The following is a description of a gene set: species: Mus musculus Any process that activates or increases the frequency, rate or extent of the chemical reactions and pathways resulting in the breakdown of substances. Mouse Gene Set: GOBP_POSITIVE_REGULATION_OF_CATABOLIC_PROCESS, and this is the list of marker genes: Pabpn1l, Pip4k2b, Cblb, Tlr9, Ikbkg, Usp20, Ubxn2a, Vdac1, Piwil4, Grsf1, Abca2, Vgll4, Samd4b, Htt, Sh3bp4, Ptpn1, Tnrc6c, Dtl, Cav1, Apoh, Amer1, Mlst8, Nupr1, Igf2bp1, Rnf152, Vps28, Gpsm1, Rhbdd3, Rnf40, Slc25a4, Ecscr, Clec16a (C-type lectin domain family 16, member A), Atg5, Ago2, Tnrc6a, Vsir, Rgma (NCBI Gene Id 244058), Pip4k2a, Wnt5a (NCBI Gene Id 77565), Sox9, Egln2, Qki, Esrrb, Axin2, Idua, Plk2, Slc35d3, Trim67, Ripk2, Csnk1a1, Rnf31, Ezr, Asb5, Fto, Adrb2, Sec22b (NCBI Gene Id 99656), Rab12, Eif2ak1, Ager, Hspa1a, Ago3, Hnrnpu, Trp53inp1 (transformation related protein 53 inducible nuclear protein 1), Fxr2, C4bp, Cop1, Bag2, Gja1, Ormdl3, Xbp1, Zc3h12a, Abcd1, Pan3, Lrp1, Hnrnpr, Trib1, Tsc1, Arnt, Mlx, Zyg11b, Irs2, Sumo1, Dab2, Cbfa2t3, Phkb, Mylip, Snf8, Irs1 (NCBI Gene Id 16367), Rab3gap2 (NCBI Gene Id 98732), Nanos3, Prkce, Mir451a, Akt1, Svip, Celf1 (NCBI Gene Id 98760), Ccny, Fgf21, Trf, Nrdc, Zfp36l3, Ptk2, Lin28b, Zdhhc19, Stx5a, Atg7, Mlh1, Apoa5, Lpcat1, Foxo3, Rb1cc1, Mettl3, Akt2 (thymoma viral proto-oncogene 2), Wfs1, Stub1, Ube2a, Bag6, Mlxipl, Eif2ak3, Rbx1, Polr2g, Nanos2, Sumo3, Apoa4, Deptor, Tut7, Zp3r, Sctr, Laptm5, Mir7578, Git1, Cnot1, Gga1, Rufy4, Supt5, Cnot7, Ythdf1, Optn, Gigyf2, Dapk1, Kcne2, Setd2, Pabpc1, Phkg2, Pink1, Ptk2b, Atm (NCBI Gene Id 77416), Bnip3l, Tut4, Chfr, Cnot6l, Smo, Hnrnpd, Apoe, Vcp, Mapk3, Kat2b, Hsp90aa1, Cnot6 (NCBI Gene Id 216722), Ubr4, Zc3h18, Rc3h1, Gata5, Hspb8 (heat shock protein 8), Tbk1, Gck, Gtpbp1, Trim8, Mul1, Apc, Tob1 (transducer of ErbB-2.1), Trim21, Map3k7, Abcd2, Mtln, Ralb, Adcy10, Mir144, Fbxo7, Hsf1, Csnk1e, Snx4, Pde12, Vps35, Samd4, Gpld1, Tmem67, Nub1, Adra2a, Rbx1-ps, Slc4a4, Prxl2c, Sqstm1, Sorl1, Rock1, Wipi1, Snx1, Prr5l, Hmox1, Dhx9, Slc25a5, Wdr24, Dcn, Uchl1, Nkd2, Patl1, Twist1, Cd81, Mtor, Btg2, Sumo2, Ube2v2, Elapor1, Cdc20b, Acsl5 (NCBI Gene Id 71879), Snx33, Sh3d19 (NCBI Gene Id 99866), Pcsk9, Faf1, Dhx36, Sgsm3, Mir196a-1, Trim23 (NCBI Gene Id 81003), Il1b, Zbtb20, Pabir1, Prickle1, Piwil1, Dnajb2, Dcp2, Sptlc2, Oaz2, Apoc2l, Wac, Zfp36, Trim13, Sesn2 (sestrin 2), Syncrip, Mefv, Supv3l1, Prkd1, Tnrc6b, Bax, Zer1, Apoc2, Prkn, Phka1, Nod1, Ufl1, Mettl14, Sh3rf2, Tent4a, Tmx1, Lrsam1, Fxr1, Ulk1, Becn1, Smurf1, Gsk3b (NCBI Gene Id 98033), Tnfsf12, Igf1, Lrrk2, Sirt6, Hamp2, Ifng, Ldlr, Atg2a, Fbxw7, Snx9, E330034G19Rik, Bid, Src, Mir196a-2, Pafah1b2, Rnft2, Gnai3, Agtpbp1, Sh3rf3, Oaz3, Gpd1, Trim32, Zswim8, Ndufa13, Paqr3, Pacsin3, Aadac, Elavl1, Ddb1, Parn, Khsrp (KH-type splicing regulatory protein), Bag3, Cdk16, Cul4b, Zfp36l1, Larp1, Gclc, Rock2, Pnldc1, Atg13, Fbxl5, Det1 (DET1 partner of COP1 E3 ubiquitin ligase), Ern1, Ier3, Ppp2ca, Dxo, Piwil2, Tiparp, Hamp, Il4, Sptlc1, Actn3, Rilp (Rab interacting lysosomal protein), Caprin1, Snx7, Fzr1, Agbl4, Mtdh (NCBI Gene Id 67154), Ddit3, Myc, Trim71, Hmgb1, Bbs7, Abhd5, Epm2a, Mov10, Psen1, Dnd1, Paip1, Pnpt1, Zc3hav1, Nprl3, Tnfrsf1b, Tlr2, Alkbh5, Nnt, Mapk8, Nsf, Cpt1a, Gabarap, Atg4b, Pip4k2c, Sh3glb1, Tom1, Pum1, Hif1a, Atg16l1, Cdkn1b, Plekhf1, Ang, Usp5, Atg101, Ythdf3, Angptl3, Fmr1, Rbm24, Mid2, Mex3d, Cnot3, Huwe1, Ticam1, Pfkfb1, Adra1b, Marchf2, Kdr, Eif4enif1, Mdm2, Daglb, Obp2a, Prkaa2, Atxn3, Rnf185, Tomm7, Sesn1, Atp5if1, Tgfb1i1, Pten, Gtsf1, Mir196b, Zfand2a, Psmd10, Irgm1, Aurka, Adam8, L3mbtl3, Mapk15, Ubr3, Ubqln2, Dcp1b, Upf1, Tmtc3, Gga3, Atf6, Rnft1, Gapdhs, Ins1, Sox17, Rhbdd1, Asb9, Fyco1, Fabp1, Apoa2, Bnip3, Htr2a, Tnf, Enpp7, Socs4, Sting1, Vps13d, Rab3gap1, Csde1 (NCBI Gene Id 99530), Trib3, Rnf139, Hspbp1, Nprl2, Tent4b, Plekhn1, Bcl2l11, Gpi1, Il33, Rida, Rack1, Sct, Nedd4, Pan2, Depdc5, Nedd4l, Patl2, Igtp (interferon gamma induced GTPase), Bcap31, Calcoco2, Phkg1 (phosphorylase kinase gamma 1), Klhl40, Tnfaip3, Snx30, Plk1, Crebrf, Cnot8, Clstn3, Adam9, Dcps, Sgta, Prkaa1, Irgq, Rdx (radixin), Oaz1, Eif2a, Cdk5rap3, Map2k1, Dvl1, Foxo1, Asb11, Plin5, Sh3rf1, Traf7, Csnk1d, Snca, Herpud1, Ins2, Hdac6, Gba1, Pik3c2a, Ddrgk1, Tardbp, Lsm1, Snx18, Dis3l2, Nkd1, Dele1 (DAP3 binding cell death enhancer 1), Mir451b, Dcaf1, Rc3h2, Kat5, Rnf180, Tsc2, Scoc (NCBI Gene Id 80484), Ythdf2, Mettl16, Dda1, Trim30a, Nod2, Mapk9, Psen2, Vip, Ndfip1, Insr, Sirt1, Rptor, Fbxo22, Tfeb, Prkcd, Fbxo11, Noct, Tpcn1, Moap1, Irgm2, Ambra1, Dcp1a (decapping mRNA 1A), Osbpl7, Trem2, Ubqln1, Clu, Stk11, Adora1, Ccdc22, Dtx3l (NCBI Gene Id 209200), Pias1, Cdc20, Nanos1, Ttc5, Tmem259, Sik2 (NCBI Gene Id 235344), Dact1, Rab7, Trim65, Disc1, Hspa1b, Cul4a, Il6, Cpeb3, Smcr8, Sirt2, Ifnb1, Vps11, Cers1, Pttg1ip, Sesn3, Axin1, Trib2, Igfbp3, Gpc3, Endog, Flcn, ENSMUSG00000144291, Fbxw8, Pnpla2, Rchy1, Rad23a, Nop53, Zfp36l2, Pim2, Usp13, Csnk2a1, Ybx1, Rnf41 (NCBI Gene Id 75676), Plk3, App, Ppp2r3a, Dab2ip, C9orf72, Egf, Socs5 (NCBI Gene Id 69052), Zc3h12d, Gsk3a, Itch (NCBI Gene Id 77732), Wdr45, P2rx7, Cnot2, Msn, Hk2, Cdc37, Tmem59